The following is a description of a gene set: from publication Wong AW, Brickey WJ, Taxman DJ, van Deventer HW, Reed W, Gao JX, Zheng P, Liu Y, Li P, Blum JS, McKinnon KP, Ting JP (PMID 12910265) studied in species Homo sapiens Human Gene Set: GSE557_CIITA_KO_VS_I_AB_KO_DC_UP Genes up-regulated in dendritic cells: CIITA knockout versus I ab-/- mice. Triplicates preparations of RNA from day 10 DC's. Experiment is described in Wong et al 2003 Nat. Immunol., and this is the list of marker genes: TLR7, PPFIA4, CRTC1, HOPX, RELCH, CAMKMT, XAF1, UBXN6, KLHL1, MAPKAPK3, IGBP1, LFNG, GIMAP1, AMZ1, FAM120B, RHBDD1, MPV17, GPR137B, GIMAP6, IFT25, PPIB, TRIM34, MYO1C, ZNF318, WDFY1, RARA, P2RX4, ERO1A, TVP23B, KLF12, CD82, THBS3, FGD3 (NCBI Gene Id 89846), EVA1B, B4GALNT1, CLCN5, EVI2B, HMG20A, RELL2, KCTD21, ATXN1, QSOX1, SLC4A10, NAT9 (NCBI Gene Id 26151), MAP3K8, AGRN, DNAJB2, TBC1D10C (TBC1 domain family member 10C), HLA-E, S100A11, ABHD11, NPC2, CZIB, RAPGEF4, SAMD9L, CYP2D6, TMEM31, SPART, PLEKHB2, B4GALT5, SBNO2 (NCBI Gene Id 22904), CYB561A3, SMC6 (NCBI Gene Id 79677), LENG9, ETV3, BATF, MARCKS, GPATCH2, BATF3, SOCS3, PDLIM5, KLF4 (KLF transcription factor 4), GPR108, SGPL1, GMFG, CKAP4, TENM4, CFP, PPCDC, TRIAP1, TBRG1, EXT1, SSR4, BMI1, TPPP, AKAP7, FKBP11, CREBZF, UVSSA, TBC1D17, MACIR, GBP4, SURF1, DNM3, RIMOC1, SLC35F5 (solute carrier family 35 member F5), RP2, ST8SIA6, NCF1, NCF2, TMCC3, SDF2, PXN, CARD19, KHNYN, MICU3, TPRA1, PBXIP1, GLB1L, GRB7, HLA-DOA, APP, BCL2L11, NDFIP1, EDEM2, CTPS2, RNF2, STX17, CD84, ZDHHC14, PMEPA1, PIGX, MLLT6, TLE3, FGL2, IER5L, RUNX3, PDLIM2, RAPGEF6, LGALS9B, PLP1, UCKL1, SRI, SLFN12L, ULK2, HLA-B, ARID3B, POU2F2, DENND2D, SERPINB9, LITAF, ARL4C, PDLIM1, NKTR, GBP7, IFNAR1, BST2, ANKRD44, CD40, SHISA5, MTFMT, CREBL2, TSPAN2, MRPL30, CARD6, ARMC3 (NCBI Gene Id 219681), TBC1D14, CYTH4, SLC46A3, SLC43A1, LY86, DDRGK1, KRTCAP3, STMP1, DSE, MTERF3, XPA, ACP6, LRRC8A, COQ10A, PLEKHA6, RAD52, PARM1, TNFRSF1B, EBPL, AHCYL2, ICA1, NR4A2, ZNF524, IFI27L2, IFI30, BBS9, TNFRSF18, TMEM50B, MDP1, BMP8A, NUDT17, NAPSA, CD1D, SH2B3, DUSP11, PTGER1, STRIP2, MPEG1, PGLYRP2, JUNB (NCBI Gene Id 90482), CISH, KBTBD11, LGALS4, RECK